The following is a description of a gene set: species: Mus musculus DDX58/IFIH1-mediated induction of interferon-alpha/beta Mouse Gene Set: REACTOME_DDX58_IFIH1_MEDIATED_INDUCTION_OF_INTERFERON_ALPHA_BETA, and this is the list of marker genes: Pin1 (peptidyl-prolyl cis/trans isomerase, NIMA-interacting 1), Ager, Uba52rt, Hmgb1, Ep300, Nfkbia, Ubc, Irf7, App, Nkiras2, Cyld, Rps27a, Chuk, Tax1bp1, Hsp90ab1, Ubb, Rela, Tnfaip3, Nfkb2, Tbk1 (TANK-binding kinase 1), Nkiras1, Ikbkg, Nfkbib, Rigi, Ikbke, Tomm70a, S100b, Irf3, Mavs, Hsp90aa1, Uba52, Nlrx1, Nfkb1, Ikbkb